Given this list of marker genes FAM83B, ZFAND3, LILRA1, RAB10, ATL2, RSBN1, PSTPIP2, ANP32B, MRPS23, TAF4, SYT1, FURIN, HES5, GDI2, CRY1, FGF12, ACTN1, TMEM230, EHMT1, SCN8A, CSTF3, GCSAML, PCDH17 (protocadherin 17), MIGA1, FAM241B, CLTRN, SMURF2, RDX (radixin), FAM81A (NCBI Gene Id 145773), CTBP1, CNBD2, ZBTB14, ZNF235, SLC39A2, CNOT8, TAB2, TICAM1, MND1, XIAP, B3GALNT2, SKIL, CAPN6, PTPRB, RNF111, RASGRP1, BROX, PRSS35, CCDC107, ATG14, SRSF10, GFPT2, TMEM169, here is a description of the gene set: Genes predicted to be targets of miRBase v22 microRNA hsa-miR-676-3p in miRDB v6.0 with MirTarget v4 prediction scores > 80 (high confidence targets). from publication Chen Y, Wang X (PMID 31504780) studied in species Homo sapiens Human Gene Set: MIR676_3P